The following is a description of a gene set: species: Mus musculus The global programming of epigenetic modifications in the zygote following fertilization. The paternal genome undergoes active DNA demethylation before the first cell division, while the adjacent maternal genome is protected from this process. Mouse Gene Set: GOBP_EPIGENETIC_PROGRAMMING_IN_THE_ZYGOTIC_PRONUCLEI, and this is the list of marker genes: Ddb1, Axin1, Kdm1b, Suv39h1, Dcaf13, Zfp57, Meg3, a, Zfp445, Mettl23, Stpg4, Dnmt3l, Tet3, Morc1, Dppa3, Suv39h2, Tet1